The following is a description of a gene set: species: Homo sapiens Human Gene Set: GSE15767_MED_VS_SCS_MAC_LN_UP LN resident macrophages lining the lymphatic sinuses play critical roles in antigen capture and presentation as well as degradation. We used microarray to examine global gene expression profiles to compare SCS and med macrophages to determine the underlying molecular basis of their differential handling of antigens. Genes up-regulated in comparison of medullary macrophages versus subcapsular sinus (SCS) macrophages. from publication Phan TG, Green JA, Gray EE, Xu Y, Cyster JG (PMID 19503106), and this is the list of marker genes: CTF1, PHYHD1, TMCC3, PID1, GAB1, DOCK7, TMPRSS4, FCER1G (Fc epsilon receptor Ig), B3GALNT1, HYCC1 (hyccin PI4KA lipid kinase complex subunit 1), ALDH2, TSPAN3, NRP2, PKIG, TREX1, TENT2, TSPAN6, MSR1, IFITM3, CLEC7A, MTCL2, CLN8, STARD5, LPIN1, NECTIN4, OSBPL11, CPQ, NLN, ABCA1, UNC93B1, ADGRL2, RAB38, PLBD1, STARD8, MIR99AHG, PROK2, MYH10, INPP4A, DSE, PTPRO, MCEMP1, CSF2RB, FNIP1, GSN, NOD1, SLAMF8, PRKCD, CAPZB, DBI, SMTNL2, RBM47, ASPH, METRNL, GPRC5C (G protein-coupled receptor class C group 5 member C), CD68, HLX, FCRL1, BTNL2, NCAPG2, ERG, TEP1, PYROXD2, PLEKHG5 (NCBI Gene Id 57449), PRKAR1B, KIF23, IFITM2, FCGR3A, INMT, LY86, DACT2, CDS1, NINJ1, CPA3, NFXL1, MAG, ASAH2 (N-acylsphingosine amidohydrolase 2), ATP6V0B, KRT80, F11R, CREG1, PGPEP1, NPC2, TSLP, DUSP22, MORF4L1, LMO2, FLACC1, SIGLEC1, RALB, TNFRSF21, SELL, SLAMF9, SUSD3, IDH2, TMEM150B, ACSS1, HSPA12A, PDGFC, CALHM6, ARPC5, TLR5 (NCBI Gene Id 95519), THBS1, NRAP, RAB31, CTNND1, ERLIN1, REPS2, GZMA, TENT5A, KPNA7, AGO4, KCNMB2, PMP22, NCKAP1L, HOMER1, RTL5, NCF1, EPB41L3, ACP5, TLR4, TPPP, APBA1, HYAL2, EIF1AY, NOTCH2, TEKTIP1, C6, CALML4, DPY19L1, TLR8, CLEC10A, SLC7A7, CYBB, SEPTIN10, NUCB2, RNF180, HLA-DQA1, HLA-DRB1, ACVRL1, LYN, MSRB1, DSTN, NADK, TREML4, GAS6, NIPA2, PROS1, MAN2B2, IRF8, FOS, KLHL9, FXYD2, SASH1, NFIC, PHOSPHO1, PTPN6, ASAH1, ATP13A2, SRL, NKPD1, ASGR2, ZEB2, SELENBP1, CLVS1, MFSD1, SKAP2 (src kinase associated phosphoprotein 2), STAB1, IFNAR2, KCNK13, P2RY6, STEAP3, LRP1, NAGLU, HSP90AA1, GPR160, CYRIA, ANXA5, TMEM106A, TCN2, IQGAP2, RNASE6 (ribonuclease A family member 6), RAB11FIP5, YIPF1, ADAM9, LRP4, FPR2, BHLHE22, MANBAL, C5AR1, MYO1C, IL10RB (NCBI Gene Id 3588), DOCK4, BFSP1, EPHA4, CYBC1, MEF2A, GPR35, MTMR6, CD276, HNMT